Given this list of marker genes CD2AP, APOL1, INF2, ANLN, NPHS2, SMARCAL1, COQ8B, ACTN4, LMX1B, ANKFY1, NUP160, TBC1D8B, ARHGAP24, PAX2, ZAP70, MAGI2, CRB2, NPHS1, COL4A3, DAAM2, KANK2 (NCBI Gene Id 55598), NUP93, KIRREL1, WT1, NUP37, NUP107, NUP85, NUP205 (NCBI Gene Id 23165), NUP133, MYO1E, PLCE1 (phospholipase C epsilon 1), ARHGDIA, GAPVD1, EMP2, PTPRO, LAGE3, ARPC5, TRPC6, here is a description of the gene set: Human Gene Set: HP_MINIMAL_CHANGE_GLOMERULONEPHRITIS species: Homo sapiens Minimal change glomerulonephritis The presence of minimal changes visible by light microscopy but flattened and fused podocyte foot processes on electron microscopy in a person with nephrotic range proteinuria.